The following is a description of a gene set: The process in which a purine nucleoside is transported across a membrane. A purine nucleoside is a purine base covalently bonded to a ribose or deoxyribose sugar. species: Mus musculus Mouse Gene Set: GOBP_PURINE_NUCLEOSIDE_TRANSMEMBRANE_TRANSPORT, and this is the list of marker genes: Slc25a26 (solute carrier family 25 (mitochondrial carrier, phosphate carrier), member 26), Slc29a2, Slc29a1, Slc28a2, Slc28a2b, Slc28a3